Given this list of marker genes ARHGAP33, B3GNT2, BCL11B, PLEKHG4B, SLITRK1, MAP3K13, RUFY3, CTNNB1, RIMS1, DAB2IP, CHL1, VEGFA, RASAL1, NR4A2, ZFYVE27, CDH7 (cadherin 7), ARHGEF28, NRP2, STAU2, TNIK, C9orf72, AURKA, MYO9B, SYT17, NFIB, CAPZB, RAPGEF2, VPS33A, STRC, TRIM46, ATL1 (NCBI Gene Id 6681), MYH10, NHERF1, BTBD3, TRIOBP (TRIO and F-actin binding protein), STRADB (STE20 related adaptor beta), WNT5A, CAPRIN1, TAOK3, NKX6-1, SSH1, MPIG6B, CDC42SE2, PARP6, MAP2, GRHL2, ZDHHC17, SEMA4D, CASP9 (caspase 9), ARHGEF2, ATP7A (ATPase copper transporting alpha), SH3D19, PDLIM5 (NCBI Gene Id 10611), PTPRM, LST1, SHTN1, FGD4, IL1RAPL1, PTPRS, CLDN3, WDR1, MFSD2A, PTPN11, ANAPC2, PLEKHG4, IQGAP1, SH3GL2, NRCAM, EZR, CUL7, TRAK2, CTNNA2, PDPN, SGK1, SPART, STK11, FEZ1, TANC2, KIF1A, LEF1, PTPRJ, ISL2 (NCBI Gene Id 94725), NFATC4, PLA2G10, TMEM106B, CLDN4, F2, TTC8, RTN4, NYAP1, SIPA1L1, CORO1A, RELN, CDH12, C1GALT1C1, ULK2, PAX2, B4GALT6, RASA1, EPHB2, FN1, ROBO4, GATA3, APBB2, PROX1, HDAC6, FLOT1, UGT8, GOLGA4, NEO1, MAP2K2, NTNG2, POU3F2, FGD2, DRD2, BBS1, FBXW8, SEMA6B, ADAM8, DAB1, EFNA5, SHROOM3, PAK1, DSCAM, MSX1, PLXNC1, NEFL, SHROOM1, FEZF1, PPP3CA, DNMBP (NCBI Gene Id 23268), TGFB2, LRATD1 (NCBI Gene Id 654112), MAEL, CFL1, CELSR2, CDK5R2, PTPRZ1, SEMA5A, RAB25, APLP1, SEMA4C, SNX2, ITGB2, KIAA0319, ACTG1, LHX2, MCF2, IL7R, FRMD6, LYN, GARIN3, ID1, POSTN, PITPNA, ADCY10, PRKCQ, EPS8, USP33, MEGF8, FRYL, DNAAF3, GPM6A, EGR2, DTNBP1, CDC42EP2, ISL1, DAG1, UNC5C, HEG1, TSC22D4 (TSC22 domain family member 4), SKOR2, BCL11A, FMNL3, EVL, GARIN4, CAP1, ITGB1, LGI1, BOC, CRB1, RGMA, ZMYM3, SEMA4A, TBC1D20, TNR, EFNB3, DISC1, PHIP, FGR, SIPA1L3, FGD5, SLITRK4, NRXN1, CPNE5, TBC1D24, DICER1, MYO9A, ANXA1, PRDM8, FLNB, PLXNA3, TNFRSF12A, NOG, CDH19, SEMA6C, PARD6B, RHOBTB1, MNX1, CDC42, WTIP, RAC3, HECW2, ETV1, LRRK2, KIRREL3, PLXNB2, ANO1, LHX4, CCL2, DIP2B, SLC30A1, DPYSL5, APOE, ITGA7, ACTL8, UNC93B1, GRXCR2, BSG, UNC13A, PTPRD, SLITRK5, KNDC1, PALM, USH1C, TIAM1, NR4A3, ALCAM (NCBI Gene Id 214), ACTBL2, HPRT1, ATF4, PARVG, CFAP43, GBX2, LUZP1, LLGL1, KIF5C, SCRIB, BAIAP2, SCN11A, WASF1, MDK, PHOX2B, TRAK1, CHODL, DAPK3, SLC23A2, DOCK7, ARHGEF25, CCK, TBCCD1, MET, CDH15, SPG21, ERMN, ATOH1, SYT14P1, VSIG1, PGRMC1, LZTS3, CASP3, PKHD1, DDR1, CFAP410, DMTN, CRYAA, TMEM108, TNN, PSEN1, APP, EPHB3, ODAD3, CREB1, HOXA2, SEMA5B, WNT3, ARMCX5-GPRASP2, RHOQ, SPAG6, TUBA1A, PLEKHO1, PAK6, PRPF40A, OLFM1, CNP, ABI2, VHL, STRIP1, PRDM14, EDN2, DHX36, SMAD4, TBR1, TPM4 (NCBI Gene Id 7171), DCDC2, NEDD4L, SYT3, RTN4R, RHOU, SEMA3G, LIPA, ZMPSTE24, MYO10, CNTN6, CDH22, RHOBTB2, WNT3A, ST14, NIN, VANGL2, PRKCA, CDC42EP3, NRDC (NCBI Gene Id 4898), FYN, EDN3 (NCBI Gene Id 1908), SLC1A3, LRRC4C, CCDC146, CPNE9, CUL3, EFNA4, MPL, CTTN, ARHGAP4, SLIT2, NTF3, RHOJ, ST8SIA2, FGF13, SARM1, CLIC4 (NCBI Gene Id 25932), CDH5, EDNRA, POTEI, F11R, ENPP2, KIFC2, ATOH7, LAMB2, LZTS1, ARHGEF26, CLASP2 (NCBI Gene Id 440948), TPM1, KIFBP, DLG1, POC1B, CNTNAP2, ITPKA, PRKDC, CLRN1 (NCBI Gene Id 7401), SEMA6A, ADGRB1, LLPH, RAC2, GLI2, PTN, SHROOM4, CCL24, ANOS1, SYT4, P2RX7, ECE1, POU4F3, MAPK8IP2 (NCBI Gene Id 51748), RB1, RPS6KA5, SPAST, CHRNA7, PLOD3, KLF2, MAP1S, CDH9, RND2, HOXA13, ZFPM1, NCKAP1, NGFR, ADGRB3, B4GAT1, CD2AP, ZNF385A, ARL13B, KIF5A, EFNA3, LHFPL5, DIAPH1, SEMA3F, NTN1 (NCBI Gene Id 9423), CDC42SE1, WDR19, FGD1, ITGA1, FOXB1, SHANK3, EPHB6, CERT1, PICALM, BRWD3, NPTN, DACT2, GPRIN3, CPNE6, ZMYM6, POTEE, TAL1, PALLD, SRCIN1, FZD4, ATP10A, HPN, STXBP1, NRN1L, SULT4A1, LAMC3, FAT3, ATG16L1, PARVA, ARHGAP44, NLGN1, APBB1, FAM171A1, LATS1, FRY, BCL7A, CDK5, WDPCP, ARPIN, LHX3 (LIM homeobox 3), SEPTIN7, MUL1, RAB8A, RAB3A, UST, LRP4, PEAK3, DVL3, SKIL, PALM2AKAP2, RPL24, HCK, NOTCH2, PTK2, CDH4, METTL3, LATS2, BMP7, DRAXIN, LIMK1, DVL1, SMO, SLC39A12, ABITRAM, SOX17, EPHB1, ROBO3, TUBB3, NODAL, DSCAML1, EVX1, FSTL4, FLRT3, WASF3, NTN3, EFNA1, CACNG7, SHROOM2, CDHR3, LHX9, MAP4K4, SART3, CDH3, LPAR3, NOVA2, MYCBP2, RAC1, MARK2, LMO4, SEMA3E, L1CAM (L1 cell adhesion molecule), ZDHHC15, CDC42EP1, IST1, SS18L1, PTPRO, POTEF, PAK3, KIDINS220, NEFH, CNTN2, CDH18, ULK1, CCDC88C, PPP1R12B, RILPL1, COCH, TRPV2, CTNND2, TIAM2, NECTIN1, YWHAH, EIF2AK4, WDR47, EFNB1, NEGR1, ROCK1, DIP2A, SLC9A6, SEMA3A, TSKU (tsukushi, small leucine rich proteoglycan), STK4, ALDOA, SIDT2, PTPN6, CYFIP2, ENAH (NCBI Gene Id 55740), PARVB, BAP1, COL6A1, MYL12B, FBXO45, PLXNB1, GDNF, BRWD1, BCL9L, ARHGAP35, PAFAH1B1, CAP2, ARHGEF7, BMPR1B, OSTN, WASF2, WNT7A, MSN, CCDC39, SEMA4B (semaphorin 4B), ARX, POU4F2, TECTA, BARHL2, ADNP, EDN1, SLC11A2, EPHA10, ARAP1, PRICKLE1, TTL (tubulin tyrosine ligase), MAP1A, SPTA1, HES1, PPP1R12C, RREB1, PLXNB3, BRAF, ITPR1, NPR2, RERE, DOCK10, EMB, LYPLA2, KIAA1755, EPHA3, SPINT2, ZRANB1, VIL1, SLITRK3, CHN1, THY1, PALMD, CCL13, POU4F1, PCDHAC2, BMPR2, PDZD7, LPAR1, ERBB2, IMPACT, DCLK1, PLS1, NEUROG3, USP9X, FMNL1, CD44, DLG4, CABP4, ASXL1, UNK, PRAG1, CHRNA3, CYFIP1, EPHA7, LRP8, RNF157, PREX2, SNX1, TPRN, SLIT1 (slit guidance ligand 1), NOTCH3, WNT7B (NCBI Gene Id 7477, Wnt family member 7B), DBN1, FOXG1, MIR21, TBCE, MICOS10-NBL1, BRSK1, ECT2, VCL, CNTNAP1, TNMD, TGFB1, SPAG9, SEMA4F, SPG11, LAMA2, HMCN2, GNAT2, NRN1, CFAP44, S100A6, NR2E1, BVES, PTK2B, UCHL1, NBEAL2, MATN1, CAMK2B, CRABP2, CUX1, PAX6, NKX2-1, WEE1, FGF8, MAG, GREM1, PRKCZ, VASP, CXCL12, ELAVL4, NOTCH1, KALRN, WHRN, KIF5B, SPRY3, NCKAP1L, GATA1, VAX1, NTNG1, FITM2, PPP3CB, ITGA4, VDR, OPHN1, MYOT, EP300, DMRT1, OBSL1, LRP2, CAPRIN2, CDH24, CCL7, GLI3, CLU (NCBI Gene Id 1191), ADAM7 (ADAM metallopeptidase domain 7), NDP, KLHL10, STMN1, FGD3, POTEKP, CORO1C, MINK1, GAP43, FMNL2, EFNA2, AP3B1 (adaptor related protein complex 3 subunit beta 1), MOV10, TRIO, CDHR1, EPHA8, CCKAR, ACTN1, EEF2K, MYH9, SYNE3, GJE1, UBB, MACF1, CCL3, STC1, SHOX2, ABL1, BRSK2, ITGB6, SPI1, ABI3, PLXND1, SYT1, CCL11, PTEN, CDH13, RAPH1, ZNF365, NTRK1, MAPK14, RNF6, RET, CFAP418, HGF, NELL2, KLK8, CORO1B, RILPL2, CRPPA, SLIT3, B4GALT5, FES, CRYGB, CDH17, PTCH1, UNC5A, ARTN, FOSL2, PAK2, NLGN3, KIF21A, MYO7A, FARP1, SMURF1, NGEF, NTN4, NEXN, C12orf57, PECAM1, GDI1, ZEB2, TWF2, CLEC1B, EPHA2, XK, AGO4, EMX1, ADORA2A, VAX2, PTK7, FLNA, HECW1 (HECT, C2 and WW domain containing E3 ubiquitin protein ligase 1), PRKG1, NOX4, GAS2, PDZD8, EPB42, DRGX, SYNGAP1, SEMA7A, SCN1B, CDH20, MYPN, SS18, KANK1, ZNF335, AR, PPFIA2, SPP1, STRIP2, SPARC, GRIP1, CFDP1, CDH2, CNTN5, TLX2, VPS54, CDH11, UNC5B, ANKRD27, TOP2B, ANK3 (NCBI Gene Id 288), AMOTL2, SLC26A5, CNTN1, CPNE1, TCTN1, MEF2A, SEMA3C, RHOA, GFRA3, ARMC2, SH3KBP1, TRPC6, LMX1A, GNA12, KEL, POTEJ, POF1B, ARHGAP18, IFRD1, OR10A4, DCC (DCC netrin 1 receptor), SSNA1, MAP2K1, BDNF, ARHGAP15, ATP9A, PTPRH, YTHDF1, SLITRK2, SIN3A, PHACTR1, PALM3, AUTS2, FOXD1, TTYH1, METRN, GP1BA, SRC, FZD3, FLRT2, STK25, IGF2BP1, HEXB, ABLIM1, SRF, CDH1, VLDLR, PLEC, GSK3B, GBX1, RAB21, SYT2, NOTCH4, NTF4, GAREM2, KIF13B, GNA13, NUMB, ISLR2, HEXA, GORASP1, GAS7, MFAP2, MEF2C (myocyte enhancer factor 2C), PLAA, FEZ2, FBLIM1, EGFR, LHX1, SEC24B, SLC39A3, PACSIN2 (protein kinase C and casein kinase substrate in neurons 2), C15orf62, NPTX1, SEMA3B, ITSN2 (NCBI Gene Id 6454), CDH26, AFG3L2, GRXCR1, VPS13A, MAGI1, CIB1, ARK2C (NCBI Gene Id 494470), ANKRD24, DCAF17, THOC2, SEMA3D, FEZF2, KIT, TUBB2B, NRXN3, TBCD, NES, ADCY1, YAP1, FERMT2, CDH10, COL25A1, NKX2-8, BCL6, FAT1, LIF (LIF interleukin 6 family cytokine), CSF1R, MAP6, PLXNA4 (NCBI Gene Id 91584), NF2, GPRASP3, RDX, MYH14, TUNAR, IHH, CDC42EP4, ZMYM4, S100B, EPHA6, SZT2, ARHGEF18, EFNB2, CHRNB2, EPB41L5, ABI1, MT3, ADARB1, GDF7 (NCBI Gene Id 8873), RAP2A, NYAP2, YTHDF2, CDH6, SEMA4G, CDKL3, ACTB, SHANK1, COBL, MKLN1, EXT1 (exostosin glycosyltransferase 1), KLF7, DNM2, AMIGO1, SLC25A46, NGF, FGD6, PLXNA1, RAB10, DKK1, NDEL1, CDH23, SDC2, PPP1R12A, NBL1, CLSTN3, SOD1, CSPG5, PARD3, NUMBL, LGR6, NEDD4, LIMD1, CDH8 (NCBI Gene Id 1006), NFASC, MED1, APLP2, NDN, ILK, SHH, TAOK2, ARC, CDK5R1 (cyclin dependent kinase 5 regulatory subunit 1), UPK3A, PSMB10, NCAM1, IGSF9, ARHGEF40, CNTN4, ZNF135, BAMBI, SOS1, PLPPR4, FLRT1, CUX2, CDKL5, ALS2, MYO16, EPB41L3, SIAH1, RIMS2, COL18A1, TFCP2L1, TRPC5, NTRK2, OTX2 (NCBI Gene Id 5015), BIN3, TUBB1, NFIA, UNC5D, BCL2 (BCL2 apoptosis regulator), ROBO1, ROBO2, NTRK3, PACSIN1, EPHA4, CRK (CRK proto-oncogene, adaptor protein), PQBP1, PRKN, MATN2, ID2, YPEL4, CC2D1A, CELSR3, KIF20B, CAMSAP1, EPHA5, NRP1, RYK, CDC42EP5, P2RY1, MAPT, KDR, CLRN2, DLX5, TPBG, REST, SEMA6D, ATP8A2, WASL, NSMF, MAP1B, DBNL, FGFR2, SLITRK6, SRGAP2, LARP4, RHOG, ADAM17, SPTBN4, DVL2, here is a description of the gene set: The developmental process in which the size or shape of a cell is generated and organized. Human Gene Set: GOBP_CELL_MORPHOGENESIS studied in species Homo sapiens